Given this list of marker genes PDGFRA, MMRN1, PKP2, F11R (NCBI Gene Id 50848), CXADR, MEGF11, PPIA, ILK, ACTB, EMILIN2, TSPAN32, CDHR5, PIK3CG, ADGRG1, GATA1, FERMT3, ZNF703, PTPN6, MYL9, TJP2, ACTN1, PTPRU, TNFSF11, ANK3, CLIC1, TUBB1, PDPN, MIP, MFSD2B, PEAR1, ADAMTS18, GNAS, BLOC1S4, VCL, PRKCD, TLN1, CTNNB1, CEACAM5, UBASH3B, DSP, JUP, F2RL3, TMX1, GP6, WNT3A, DSG2, DSC2, VPS33B, IL6, JAK1, IL6ST, SLC7A11, ACTG1, ALOX12, CELA2A, SYK, C1QTNF1, PLEK, FLNA, CEACAM1, PLPP3, MEGF10, COMP, TYRO3, CTNNA3, TSPAN9, RDX, MYL12A, SH2B3, CDHR2, STXBP3, SLC6A4, PDIA3, LYN, STXBP1, HTR2A, MAP2K1, PDIA2, PRKCA, XG, RAP2B, PRKG1 (NCBI Gene Id 5592), CCL5, CSRP1, CTSG, METAP1, ENTPD1, PRKCQ, JAK2, FGB, IL6R, PLAUR, CD99, FGG, PIK3CB, P2RY12, FIBP, EMILIN1, FGA, ITGB3, SERPINE2, HBB, CD9, MYH9, HSPB1, here is a description of the gene set: Human Gene Set: GOBP_HOMOTYPIC_CELL_CELL_ADHESION species: Homo sapiens The attachment of a cell to a second cell of the identical type via adhesion molecules.